The following is a description of a gene set: species: Mus musculus M Phase Mouse Gene Set: REACTOME_M_PHASE, and this is the list of marker genes: Psmc5, H2bc11, Ppp2r1a, Rad21, H2ac18, Zw10, H2ac15, Csnk1e, Prkaca, Ubb, Nek9, H2bc12, H4c6, Nup54, Cenpi, Alms1, Nup155, Cc2d1b, Tubg2, Smc4, Chmp6, Rcc2, Chmp4b, Sec13, Nup93, Tubb5, H2ab1, Cenpm, Dctn2, Xpo1, Cenpc1 (NCBI Gene Id 231379), Eml4, Lpin3, H2bc23, Gorasp2, Tubgcp2, Hdac8, Cenpn, Akap9, Dynll2, H3c15, Golga2, Mzt2, Adrm1, Anapc2, Psmd3, Nup214, Dync1li1, H3f4, Nup58, H2ac24, Rps27rt, Taok1, Cdk1, H2ab2, Seh1l, H2ab3, Spc25, Kif2c, Nup85, Cep131, Cenpl, Sgo2a, Dsn1, H2az2, Cep250, H2bc9, Tubgcp6, Psma7, H4c16, Clasp2, H2bc1, Cenpo, Haus3, H3c3, H2bc15, Uba52rt, Psma5, H2bc6, B9d2, Mad1l1, Mapk3, Nup210, Kif2a, Ccnb2, Bub1, Tuba3b, Nup107, Nek2, H2bc3, Mapre1, Ube2d1, H3c6, Banf1, Ahctf1, Psmc3, Ube2i, Smc1a, H2bc7, Ppp2r1b, Nudc, Rab2a, Ppp2r5a, Ncapg, Rangap1, Tubb6, Psma6, Kif2b, H4c3, Ndel1, Prkcb, Plk1, Vrk1, Spast, Pds5a, Ckap5, Psmb1, Cdc20, Ercc6l, Ppp2r5c, Dctn1 (NCBI Gene Id 13191), Stag2, Ppp1cc, Ssna1, Ndc1, Mau2, Plk4, Pmf1, Ist1, Tubgcp4, Kpnb1, Firrm, Ppp2r2a, Mad2l1 (NCBI Gene Id 56150), Rab1a, Nup98, Ppp2r5b, Tpr, Tubb3, Cdca5, H4c12, Ncapg2, Cep192, Numa1, Anapc1, Rps27, H3c14, Rab1b, Psmc6, Cetn2, Clasp1, H4c11 (H4 clustered histone 11), Pcm1, Tubb2a, Cep152, Tuba1a, Arpp19, Csnk2a1, Blzf1, Pds5b, Cenpt, Ppp2r5d, Ctdnep1, Ofd1, Cenpf, Chmp4c, Sdccag8, Nup42, Psmb6, H2ac23, Lmnb1 (lamin B1), Sirt2, H3f3b, Ncapd3, Ran, Ywhag, Nup37, Cdc26, Pafah1b1, Cdc23, Gorasp1, Cep76, H2bc4, Clip1, H2bc14, Tubb4a, H3c11 (H3 clustered histone 11), Nup35, H2ac8, Nedd1, Pttg1, H4c4, Anapc16, Anapc5, Odf2, Cenps, Ncaph2, Fbxo5, Chmp3, Ncaph (NCBI Gene Id 215387), H4c1, Psmd8, Ndc80, Rps27a, Anapc15 (NCBI Gene Id 75430, anaphase promoting complex C subunit 15), Rae1 (NCBI Gene Id 66679), Tubgcp5, Lmna, Cep164, H2ac7, Psmd11, Chmp2b, H4c17, Bub1b, Haus6, H2ac4, Dync1li2, Tubgcp3, H2ac6, Nup160, Nup188, Psmd14 (NCBI Gene Id 98839), Psmb2, Cep78, Incenp, Chmp2a, Psmd1, Lpin2, Psmd13, Psmd7, Smc2, Haus7, H3c4, Ppp2r5e, Nup50, Mapk1, Psma4, Zwilch, Ska2, Tuba1c, Psmb4, Nup88, Haus5, Bub3, Itgb3bp, Tubg1, Ninl, Actr1a, Dctn3, Nup62, Mcph1, Rb1, H2bc21, Ubc, Tubb4b, Cep57, Uba52, Vrk2, Haus8, Ncapd2, H2ac13, Psmc4, Psma1, Cdk5rap2, Cdc27, Vps4a (vacuolar protein sorting 4A), Rcc1, Lbr, Emd, Ranbp2, Anapc4, Psmd12, Psmc1, H2bc22, Psmd2, Dync1h1, Cdc16, Sumo1, Cep41, Ccnb1, Csnk2a2, H3c13, Ppp2ca, Anapc7, Kif20a, H2ac11, Haus1, Mis12, H3c8, Cnep1r1, Cenpq, Dynll1, Cep290, Cenpa, H4c14, H3c10, Ppp2cb, Psma2, Cep70, Tubb1, Haus2, Cep43, Sgo1, Kif18a, Csnk2b, Tuba8, H2bc24, H3f3a, Zwint, Spc24, H2bc8, Nde1, Cep63, Cep72, H2ac12, Spdl1, Cenpu, Nup133, Nsl1 (NCBI Gene Id 98359), Tuba3a, Haus4, H2ac22 (NCBI Gene Id 319170), Anapc10, Anapc11, Dync1i1, Set, Wapl, Cenpp, Psmb5, Nup43, H2bc13, Ube2e1, Dync1i2, Rbm39, H3c7, Cenpk, Mastl, Tubal3, Ywhae, Ska1, Nup153, Aurkb, H2aj, Ccp110, Chmp7, Csnk1d, Psmb3, Pom121, Cenph, Cenpj, Psmd6, Tubb2b, Espl1, Hsp90aa1, Ankle2, Smc3, Kntc1, Nme7, Psmc2, Mzt1, H3c1, Cenpe, H2ac10, H4c9, Nuf2, H4c8, Kif23, Psma3, Ube2c, H4c2, Tuba4a, Psmb7, Tuba1b, Cep135 (NCBI Gene Id 381644), H2ax, Nipbl, Aaas, Nup205, Stag1, H2ac19, Ube2s, Sfi1, H2bc26, H2ac20, Cdca8, H3c2, H4c18